Given this list of marker genes Cox10, Abcc2, Ugt1a5 (NCBI Gene Id 394433), Abcg2, Ppox, Alb, Gsta3, Uros, Blvrb, Alad, Ugt1a1, Fech, Urod, Alas2, Hmox2, here is a description of the gene set: Reactome Pathway: Metabolism of porphyrins studied in species Mus musculus This event has been computationally inferred from an event that has been demonstrated in another species.<p>The inference is based on the homology mapping from PANTHER. Briefly, reactions for which all involved PhysicalEntities (in input, output and catalyst) have a mapped orthologue/paralogue (for complexes at least 75% of components must have a mapping) are inferred to the other species. part of: Metabolism electronically inferred by orthology from the curated human pathway